Given this list of marker genes Hoxa11, Hoxd11, Otx2, Fgf8, Bmp4 (NCBI Gene Id 12159), Nkx2-2, Traf3ip1, Sostdc1 (sclerostin domain containing 1), Fuz, Hoxb2, Rab23, Gsx2, Pax6, Foxa2, Cdk20, Noto, Dll4, Ift172, Lrp6, Mdfi, Foxn4, Axin2, Bmpr1b, Cer1, Rnf220, Tctn1, Acvr1, Tmed2, Hhip, Wnt3a, Mnx1, Tll1, Mapk8, Ift52, Lrp4, Ttc21b, Rfx4, Grem1, Intu, Bmp1, Cplane2, Pax7, Gas1, Evx1, Tbx20, Grem2, Apc, Sp8, Wnt7a, Gli1, Tgif1, Nbl1, Foxa1, Shh, Lhx2, Bmpr1a, Six3, Vax2, Smo, Sfrp1, Sufu, Ascl1, Dbx1, Ctnnb1, Ovol2, Nkx2-1, Psen1, Wnt3, Foxg1, Lhx3, Kif3a, Arl13b, Nog, Edn1, En1, Gli3, Axin1, Smad6, Fkbp8, Gsc, Fbxl15, Lmx1b, Map3k4 (NCBI Gene Id 27882), Hoxa2, Ptch1, Ift88, Dync2h1, Acvrl1, Senp2, Prop1, Lhx1, Sox1, Mks1, Tbc1d32, Aida, Tulp3, Ddit3, Tll2, Psen2, Disp1, Dmrt3, Gpr161, Ift122, Smad2, Gorab, Gli2, Wdr19, Prkaca, Chrd, Prkacb, here is a description of the gene set: studied in species Mus musculus Mouse Gene Set: GOBP_DORSAL_VENTRAL_PATTERN_FORMATION The regionalization process in which the areas along the dorsal/ventral axis are established that will lead to differences in cell differentiation. The dorsal/ventral axis is defined by a line that runs orthogonal to both the anterior/posterior and left/right axes. The dorsal end is defined by the upper or back side of an organism. The ventral end is defined by the lower or front side of an organism.